Given this list of marker genes Mesp2, Kdm6a, Mesp1 (mesoderm posterior 1), Ripply1, Ripply2, Tmed2, Otx2, Foxa2 (NCBI Gene Id 15376), Epb41l5 (NCBI Gene Id 98492), Gdf3, Nrarp, Smad4, Lhx1, Tbx6, here is a description of the gene set: Mouse Gene Set: GOBP_SOMITE_ROSTRAL_CAUDAL_AXIS_SPECIFICATION The establishment, maintenance and elaboration of the rostro-caudal axis of a somite, prior to the morphological formation of a somite boundary. studied in species Mus musculus